Given this list of marker genes Pcbd2, Mthfd1, Mthfd2l, Park7, Pcbd1, Pah, here is a description of the gene set: studied in species Mus musculus The chemical reactions and pathways resulting in the formation of aromatic amino acid family, amino acids with aromatic ring (phenylalanine, tyrosine, tryptophan). Mouse Gene Set: GOBP_AROMATIC_AMINO_ACID_FAMILY_BIOSYNTHETIC_PROCESS